The following is a description of a gene set: Mouse Gene Set: GOMF_G_PROTEIN_COUPLED_SEROTONIN_RECEPTOR_ACTIVITY Combining with the biogenic amine serotonin and transmitting the signal across the membrane by activating an associated G-protein. Serotonin (5-hydroxytryptamine) is a neurotransmitter and hormone found in vertebrates and invertebrates. studied in species Mus musculus, and this is the list of marker genes: Htr2c, Htr4 (5 hydroxytryptamine (serotonin) receptor 4), Drd4, Htr1b, Htr2a, Htr5b, Htr7, Htr1d, Htr1a, Htr1f, Htr6, Htr2b, Htr5a